Given this list of marker genes COL1A2 (collagen type I alpha 2 chain), CNTN1 (NCBI Gene Id 1272), LYPD6 (NCBI Gene Id 130574), LINC01133, PKP1, PCDH7, MT1E, PFKP, SLITRK6, LGALS1, EMP1, PITX1, CYP2W1, SYTL1, PART1, FHL1, SULT1E1, EMP3, NUAK1, NPPC, EHF, HS3ST1, SOX15, RGS14, NTF3, IRAG2, LGR4, BOC, TENM4, DLK2, PTGES, RHBDL1, SULF2, OTX1, GPC3, EYA1, HSPA2, JAG2, LINC01503, PNCK, CAMK1D, DLK1, CYP2S1, NPDC1, ISL1, FAM107A, CFH, COL14A1, CHST9, GAS6, FXYD5, ANXA1, SLC20A2, LHFPL6, NRG1, TMEM150C, MEIS1, TIMP1, DPYSL3, F3, COL5A1, SOSTDC1, KRT15, FBLN2, KLK10, THSD4, ZNF385D, KRT13, NRXN3, TFAP2A, RARRES2, SERPINE2, BAALC, LYPD6B (LY6/PLAUR domain containing 6B), TFPI2, SPDEF, ADH7, LDLRAP1, TNFAIP8, ZNF385A, IGFBP4, KISS1 (KiSS-1 metastasis suppressor), COL7A1, SCGB3A1, LGALS7B, MEG3, S100A2, FBN1 (fibrillin 1), CDCP1, SNAI2, PAX9, MAOA, SERTAD4, IFI16, SFN, HCAR2, ITGB4, RGS10, NCS1, FHL2, NBL1, EVA1C, KRT5, CNTN4, PRRG4, MAFB, DST, GYPC, TP63, KRT14, SLPI, TP73, ABI3BP, OPTN, VCAN, RARB, REEP2, ELN, RMDN2, SIX1, EYA2 (NCBI Gene Id 2139), IL1RAP, LSP1, HCAR3, CH25H, MYC, SCNN1B, DKK3, COL17A1, TRIM29, LPAR6 (lysophosphatidic acid receptor 6), SPINK5, SLC5A7, A4GALT, RASSF6, PROM1, PLXDC2, SEMA3A, CAPNS2, SLIT3, SPARCL1, C16orf74, SCNN1G, NUPR1, LTB4R2, CXCL14, EPAS1, JAM3, FRZB, here is a description of the gene set: Mid basal Human Gene Set: HE_LIM_SUN_FETAL_LUNG_C1_MID_BASAL_CELL species: Homo sapiens from publication He P, Lim K, Sun D, Pett JP, Jeng Q, Polanski K, Dong Z, Bolt L, Richardson L, Mamanova L, Dabrowska M, Wilbrey-Clark A, Madissoon E, Tuong ZK, Dann E, Suo C, Goh I, Yoshida M, Nikolić MZ, Janes SM, He X, Barker RA, Teichmann SA, Marioni JC, Meyer KB, Rawlins EL (PMID 36493756)